Given this list of marker genes Rps3, Rps19, Ass1, Miox, Kcnk1, Ddt, H2-Eb1, Apob, Cox8b, H2-Aa, Rdh16f2, Iscu (NCBI Gene Id 66383), Apoe, Rpl22, Ackr3, Rps4x, Rps9, Rpl6, H2-Ab1, H2-K1, Rps13, Cbr1, Prlr, Rida (reactive intermediate imine deaminase A homolog), Rpl10a, Cd81, H1f2, Rps5, B2m, Cyp2d9, Gstt1, Mfsd4b5, Ybx1, Rpl10 (NCBI Gene Id 28147), Rps3a1, Rpl9, Aldh2, Tmem37, Dbi, Eef1a1, Rpl21, Gas5, Spp1, Ftl1, Tmsb4x, Rpl4, Cd74, Itm2b, Rps23, Tmem254, Kng2, Pdzk1ip1, Dhrs3, Cyp2a4, Hao2, Igfbp7, Cfb, Fbp2, Rplp0, Wfdc2, Gpx3, Ethe1, here is a description of the gene set: studied in species Mus musculus Mouse Gene Set: TABULA_MURIS_SENIS_KIDNEY_BRUSH_CELL_AGEING from publication Tabula Muris Consortium (PMID 32669714)